The following is a description of a gene set: To examine the impact of tumors on the immune system, we compared global gene expression profiles of peripheral blood T cells from previously untreated patients with B cell chronic lymphocytic leukemia (CLL) with those from age-matched healthy donors. Although the cells analyzed were not part of the malignant clone, analysis revealed differentially expressed genes, mainly involved in cell differentiation in CD4 cells and defects in cytoskeleton formation, vesicle trafficking, and cytotoxicity in CD8 cells of the CLL patients. In coculture experiments using CLL cells and T cells from healthy allogeneic donors, similar defects developed in both CD4 and CD8 cells. These changes were induced only with direct contact and were not cytokine mediated. Identification of the specific pathways perturbed in the T cells of cancer-bearing patients will allow us to assess steps to repair these defects, which will likely be required to enhance antitumor immunity. Gene expression profiling was performed to determine whether CLL cells induce changes in T cells in patients with CLL. from publication Görgün G, Holderried TA, Zahrieh D, Neuberg D, Gribben JG (PMID 15965501) Genes up-regulated in T cells from CLL (chronic lymphocytic leukemia) patients: CD4 versus CD8. Human Gene Set: GSE8835_CD4_VS_CD8_TCELL_CLL_PATIENT_UP species: Homo sapiens, and this is the list of marker genes: SMPX, CD69, SECTM1, FADS6, SLFN13, HS3ST1, FCGR1A (Fc gamma receptor Ia), CTNNA1, SPN, CPA3, FBLN1, FAM241A, CSF2, HELZ2, ITGB7, IER5, DAXX, TAPBPL, LHX2, GCOM1, MITD1, EMP3, SELL, BLOC1S4, WASF1, ISG15, GPR15, NRP2, SFMBT2, PSMD11, IL15RA, FZD6 (frizzled class receptor 6), FFAR4, CCL22, CLNK, ELAVL4, CCL13, FOXRED2, FPR2, C19orf47, STX11, MS4A8, SIRPB1, IRGM, DIAPH2, PRDM4, INPP1, TNFRSF18, ATP10A, REEP5, ZDHHC13, CMPK2, PDE7B, FKBP1B, PLA2G2E, VDAC3, SBK1, GZMB, ASCC3, KLRC1, RGR, CLEC10A, KATNA1, RAB21, TIAM1, IFI44L, SGCB, SPOP (NCBI Gene Id 8405), USP18, PNP, MEIKIN, KLRD1, NLRC5, HTR7, IRF7, USB1, RTP4, KDR, SERPINB9, GYPC, TMEM192, ATP8B4, RNF213, AIDA (axin interactor, dorsalization associated), SETDB2, TRNT1, PPP1R15B, FASLG, MX2, SLC41A2, IFIT3, HDC, CFB, ACTB, CCDC184, OAS3, SEMA4A, JCAD, DCAF13, SAMD9L, GNB4, IFIT1B, ALDH1L1, ICAM2, UBE2L6, HOXB1, PLCB1, OSBPL9, HSH2D, CD40, EYA3, CD207, SLC28A2, NAAA (N-acylethanolamine acid amidase), TNFSF10, HGFAC, TPH1, NT5C3A, OASL (2'-5'-oligoadenylate synthetase like), FCER1A, GATA2, TTC39B, L1CAM, MCTP2, CD3G, TLR3 (NCBI Gene Id 7098), STC1, DDX60, IFIT1, CXCL10, HAVCR1, HRH4, LGALS3, ALDH1A2, TSPO, MLKL, SAMHD1, SAP30, NMI, MARCO, CXCL11, HERC6, AGFG1 (ArfGAP with FG repeats 1), SLC30A1, IFIH1, KLRK1, CCL17, LY6E, UACA, ESYT1, OSBPL3 (NCBI Gene Id 26031), FAM72A, NMD3, RGS18, PLAT, NOTCH3 (NCBI Gene Id 791), GBP6, TNFRSF25, DGKI, RNASE6 (NCBI Gene Id 6039), CXCL9, HSPA5, MTHFR, HAT1, IL15, STAT5A, TIMELESS, SUSD2, CCL5, EIF1AX, ABTB2, DDHD1, CMA1, UPP1, MCOLN3, B3GNT2, PCGF5, ISG20, CTSG, MYO1G, IFIT2, KBTBD11, SMCR8, RSAD2, PRKCE, AKT3, IL1RL1, ZUP1, APOD (NCBI Gene Id 347), SLC37A1, PXK (NCBI Gene Id 54899), GPSM2 (NCBI Gene Id 29899), IFNG, AOPEP, PCDHB2, GBP2, RGCC, TUBB4B, IL18R1, KCNN4